The following is a description of a gene set: from publication Schaefer CF, Anthony K, Krupa S, Buchoff J, Day M, Hannay T, Buetow KH (PMID 18832364) FOXA2 and FOXA3 transcription factor networks Human Gene Set: PID_HNF3B_PATHWAY studied in species Homo sapiens, and this is the list of marker genes: FOXA3, ALAS1, KCNJ11, CEBPB, FOXA1, TAT, HNF1B, TTR, CEBPD (CCAAT enhancer binding protein delta), GCK, ALDOB, NR3C1, ACADM, HMGCS1, IGFBP1, G6PC1, PCK1, TFRC, BDH1, FOXF1, AKT1, HNF1A, ALB, HADH, FOXA2, F2 (NCBI Gene Id 14061), INS, ACADVL, NF1, PKLR, CPT1C, ABCC8, UCP2, SP1, CREB1, PDX1, AFP, CPT1A, CPT1B, NKX2-1, HNF4A, CEBPA, APOA1, SLC2A2, DLK1